Given this list of marker genes Zfp575, Sptb, Egr3, Egr2, Atp8b2, Or7d10, Rimbp2, Parp11, Cracd, Syn2, Marchf2, Srp68, Selenoi, Syngr2, Frrs1l, Nfx1, Tns1, Ezh1, Atg9a, Diaph1, Cdh4, Tmem151b, Mtmr1, Nos1, Npy4r, Nmt2, Gatad2b, Tmem198, Igf2, Ankrd49, Akt2, Atxn1l (NCBI Gene Id 78838), Ccdc85a, Cyld, here is a description of the gene set: Abstract: Trastuzumab-induced cardiotoxicity (TIC) is a common and serious disease with abnormal cardiac function. Accumulating evidence has indicated certain non-coding RNAs (ncRNAs), functioning as competing endogenous RNAs (ceRNAs), impacting the progression of cardiovascular diseases. Nonetheless, the specific involvement of ncRNA-mediated ceRNA regulatory mechanisms in TIC remains elusive. The present research aims to comprehensively investigate changes in the expressions of all ncRNA using whole-transcriptome RNA sequencing. The sequencing analysis unveiled significant dysregulation, identifying a total of 43 circular RNAs (circRNAs), 270 long noncoding RNAs (lncRNAs), 12 microRNAs (miRNAs), and 4131 mRNAs in trastuzumab-treated mouse hearts. Subsequently, circRNA-based ceRNA networks consisting of 82 nodes and 91 edges, as well as lncRNA-based ceRNA networks comprising 111 nodes and 112 edges, were constructed. Using the CytoNCA plugin, pivotal genes - miR-31-5p and miR-644-5p - were identified within these networks, exhibiting potential relevance in TIC treatment. Additionally, KEGG and GO analyses were conducted to explore the functional pathways associated with the genes within the ceRNA networks. The outcomes of the predicted ceRNAs and bioinformatics analyses elucidated the plausible involvement of ncRNAs in TIC pathogenesis. This insight contributes to a better understanding of underlying mechanisms and aids in identifying promising targets for effective prevention and treatment strategies. studied in species Mus musculus from publication Xie S, Zhou N, Su N, Xiao Z, Wei S, Yang Y, Liu J, Li W, Zhang B (PMID 38577019) Mouse Gene Set: XIE_TRASTUZUMAB_CARDIOTOXICITY_MMU_MIR_150_5P_GENES